Given this list of marker genes ADCY9 (adenylate cyclase 9), ADCY1, PRKACG, ADCY3, ADCY6, ADCY2, PTH1R, PRKACA, PTH, GNAS, ADCY5, ADCY7, PRKACB, ADCY4, ADCY8, here is a description of the gene set: studied in species Homo sapiens Human Gene Set: KEGG_MEDICUS_REFERENCE_PTH_PTH1R_PKA_SIGNALING_PATHWAY Pathway Definition from KEGG: PTH -> PTH1R -> GNAS -> ADCY -> cAMP -> PKA PTH-PTH1R-PKA signaling pathway. Pathway ID: N00288. Pathway type: Reference. Pathway class: nt06318 CaSR-PTH signaling.